Given this list of marker genes SLC35F1, PLLP, PLAT (NCBI Gene Id 5327), LHFPL3, PHLDA1 (pleckstrin homology like domain family A member 1), COL9A1, VXN (NCBI Gene Id 254778), LIMA1, MEG3, NXPH1, BCHE, ARL2BP, MPZL1 (NCBI Gene Id 9019), SNTG1, PLPPR1, TSPAN13, SEMA5A, SCN1A, TM4SF1, PCSK1N, COL20A1, C2orf80, TAOK3, BRINP3, SPRY4, PDE4B, ARL4A, CCND1, IL1RAP, APOD, LRRC4C, LRRK2, SLC1A1 (solute carrier family 1 member 1), KLRC2, GPR17, GRIA2, FIP1L1, EPN2, SNAP25, PCDH20, SCRG1, PDGFRA, ATCAY (ATCAY kinesin light chain interacting caytaxin), CXADR, CNPY2, SERTAD4BP, THY1, OLIG1, CA10, PCDH15, SCG3, BRINP1, UCHL1, CNTN1, BEX1, here is a description of the gene set: species: Homo sapiens from publication Fan X, Dong J, Zhong S, Wei Y, Wu Q, Yan L, Yong J, Sun L, Wang X, Zhao Y, Wang W, Yan J, Wang X, Qiao J, Tang F (PMID 29867213) Human Gene Set: FAN_EMBRYONIC_CTX_OPC